Given this list of marker genes MIR6888, GALNT3, PHB1P4, ENSG00000238570, IFIH1, RNA5SP111, MXRA7P1, RNU7-148P, NOSTRIN, GCA, OR7E89P, CDK7P1, PKP4, PKP4-AS1, DAPL1, RNU6-932P, MTNAP1P1, OR7E28P, XIRP2, KCNH7-AS1, GALNT5, CAPZA1P2, TANC1, TBR1, CCDC148, RNU6-1001P, RNU6-436P, RPEP5, RNA5SP110, RNU6-580P, MTND4P28, B3GALT1, LINC01806, RPLP0P7, SCN1A, ACVR1C, CCDC148-AS1, RNA5SP108, ATP5F1AP2, UPP2, AHCTF1P1, KRT18P46 (NCBI Gene Id 391458), TTC21B-AS1, MIR4785, TTC21B, PLA2R1, DPP4, SLC38A11, HEBP2P1, GALNT13-AS1, ERMN, EIF3EP2, MTND6P9, SNORA70F, MIR4774, RNU6-627P, CBX3P6, RN7SL813P, WDSUB1, XIRP2-AS1, CTAGE14P, ACVR1, RPL7P61, LINC01876, MARCHF7 (NCBI Gene Id 64844), RNU6-546P, CERS6, CYP2C56P, FIGN, GPD2, GSTM3P2, CYTIP, KCNJ3, FAP, MAPRE1P3, B3GALT1-AS1, MTA3P1, MTCO1P45, SCN2A, OR7E90P, CERS6-AS1, PSMD14, NR4A2, RN7SKP281, MTND2P20, RPL7AP22, TIMM8AP1, RNU6-766P, FAM133DP, PSMD14-DT, SCN1A-AS1, STK39, PRPS1P1, GCG, RNU2-21P, GRB14, SLC4A10, SCN3A, RNA5SP107, SCN7A, LINC02478, PHF5AP5, BAZ2B-AS1, LINC01958, CSRNP3, MTCYBP9, SCN9A, COBLL1, ITGB6, ENSG00000286679, KCNH7, RN7SL393P, RPS3AP13, RBMS1, BTF3L4P2, PTP4A1P1, TANK, CD302, BAZ2B, MTND5P30, RN7SKP152, RN7SL423P, LY75-CD302, TANK-AS1 (TANK antisense RNA 1), DPP4-DT, LY75, HNRNPDLP2, RNA5SP109, here is a description of the gene set: studied in species Homo sapiens Human Gene Set: chr2q24